Given this list of marker genes PYCARD, DHX9 (NCBI Gene Id 3450), RIPK3, TRAF6, CARD16, S100A8, PRKCI, IL18R1, HSPA1B (NCBI Gene Id 3304), CD40LG, TRIM52, NTRK1, TERF2IP, IKBKB, RNF31, CARD9, CLU, AGER, TRIM38 (NCBI Gene Id 10475), IL18RAP, ALK, CARD14, TLR4, SPHK1, FER, ERC1, TRAF5, CHUK, ARHGEF2, RIPK1, TLR2, IKBKG, MYD88, NOD2, CAMK2A, PRKD1, ZBTB7A, NOD1, CRNN, BCL10, TRIM14, MID2, PPIA, HSPA1A (heat shock protein family A (Hsp70) member 1A), TRIM5, AIM2, BTK, RELA, TNF, S100A12, RTKN2, MAP3K13, RPS6KA5, TRIM15, RPS3, RIPK4, TRIM32, PRKCQ (protein kinase C theta), RBCK1, RNF25, CARD11, EIF2AK2, PRDX3, IL18, TRIM22, RAB7B, PRKD2, PRKCH, PRKCZ, S100A9, TRIM25, LGALS9, IRAK1, DDRGK1, TRAF2, UBE2N, MTPN, TRAF1, TNFSF18, DHX33, TRIM8, NPM1, CIB1, ROR1, TRIM62, NLRP3, TRIM13, NLRC4, RPS6KA4, TRIM37, CLOCK (clock circadian regulator), RHEBL1, LTF, MTDH, here is a description of the gene set: species: Homo sapiens Human Gene Set: GOBP_POSITIVE_REGULATION_OF_NF_KAPPAB_TRANSCRIPTION_FACTOR_ACTIVITY Any process that activates or increases the frequency, rate or extent of activity of the transcription factor NF-kappaB.